The following is a description of a gene set: species: Homo sapiens Human Gene Set: HP_ABNORMAL_POSTERIOR_PITUITARY_MORPHOGENESIS An abnormality of the neurohypophysis, which is also known as the posterior lobe of the hypophysis. Abnormal posterior pituitary morphogenesis, and this is the list of marker genes: OTX2, ROBO1, PUF60, PROKR2, PI4KA, ERF, SMO, FOXA2, MTHFR, PDGFB, NF2, SMAD2, VANGL2, BAP1, TBX3, CDON, GLI2, SUFU, TERT, WDR11, GPR161, PROP1, HESX1, LHX3, KIAA0753, LHX4, ADGRG1, TRAF7, PIK3CA, DYRK1A, SMARCB1 (NCBI Gene Id 6598), SRPX2, SOX3, POU1F1, AKT1, SMARCE1